Given this list of marker genes DCC, HAO2, LINC02086, SLC22A8, WFIKKN1, OLFM3, IRX1, TNNI1, SALL1, LINC02113, KIF1A, KCNG3, PPP1R1A, ELOVL2, TMEM200C, GPHA2, SLC6A5, CLIC5, R3HDML-AS1, DEFB1, FGF8, DMRT3, RPL10P13, SLC5A8, C3orf85, RPS3AP44, DPYSL5, SLC34A1 (solute carrier family 34 member 1), CHRNA1, LINC02532, COL2A1, CALCA (NCBI Gene Id 87044), SLC47A2, ADAMTS9-AS1, TRIM71, UMOD, RIMS1, SLC3A1, DDN, ANAPC1P1, DAPL1, CLEC18C, MESP1, LINC03017, LINC03057, NPHS2, STMN4, OR51E1, LRP2, TMEM246-AS1, ENSG00000261170, SHISA9, GLYAT, SLC30A8, LINC01781, CDH6, ZDHHC22, SATB2-AS1, FAT3, NOTUM, TMEM132D, USH1C, LINC03000, PCDH15, ANKRD1, ADGRG2, RNU6-768P, SIM2 (SIM bHLH transcription factor 2), TMEM100, LINC01539, ENSG00000247416, ACSM2A, TAGLN3, PTPRQ, CLRN3, UNCX, CHRNA4, AQP6, NKAIN3, CLC, MGAM, OR51E2, PDZD7, LINC02813, SLC13A1, TCEAL2, TRABD2B, ENSG00000228033, EYA1, FOXI2, GLYATL1, UNC5B-AS1, BARX1, LINC02432, KCNC2, SHISA8, SLC6A18, ECEL1, LINC01320, RPSAP69, FAM78B, SLC12A1, KCNJ1, TRDN, LMX1B-DT, MAN1A2P1, MYO15A, SLC34A2, PRODH2, LRTM2, MMP26, SH2D5, LINC02253, ADAMTS20, KLK6, LINC01014, FAM230I, GBX2-AS1, LMX1B, CITED1, CHRNG, RBM20, PTPRO, GRIK2, ARHGEF34P, ZMAT4, ENSG00000234173, NPHS1, DPYS, LINC01896, SLIT1, LYPD1, TRPA2P, CEP164P1, MAEL, SNORA59B, VSTM2B, WT1, PCK1, AMER2, NKAIN1, KNG1, PCDH9-AS1, PROX1-AS1, SALL3, GPR176, NNAT, CASR, LINC02893, CHRND, LINC02143, COX7CP2, DNAJC5G, LINC01571, LRRTM1, CLEC18B, CLDN10, SLC17A1, here is a description of the gene set: Human Gene Set: DESCARTES_FETAL_KIDNEY_METANEPHRIC_CELLS Marker genes curated from the annotated cluster as represented in the Descartes Human Gene Expression During Development database. The gene expression program underlying the specification of human cell types is of fundamental interest. The study authors generated human cell atlases of gene expression and chromatin accessibility in fetal tissues. For gene expression, the study authors applied three-level combinatorial indexing to >110 samples representing 15 organs, ultimately profiling ~4 million single cells. The study authors leveraged the literature and other atlases to identify and annotate hundreds of cell types and subtypes, both within and across tissues. Our analyses focused on organ-specific specializations of broadly distributed cell types (such as blood, endothelial, and epithelial), sites of fetal erythropoiesis (which notably included the adrenal gland), and integration with mouse developmental atlases (such as conserved specification of blood cells). These data represent a rich resource for the exploration of in vivo human gene expression in diverse tissues and cell types. from publication Cao J, O'Day DR, Pliner HA, Kingsley PD, Deng M, Daza RM, Zager MA, Aldinger KA, Blecher-Gonen R, Zhang F, Spielmann M, Palis J, Doherty D, Steemers FJ, Glass IA, Trapnell C, Shendure J (PMID 33184181) species: Homo sapiens